The following is a description of a gene set: A nearly universal metabolic pathway in which the acetyl group of acetyl coenzyme A is effectively oxidized to two CO2 and four pairs of electrons are transferred to coenzymes. The acetyl group combines with oxaloacetate to form citrate, which undergoes successive transformations to isocitrate, 2-oxoglutarate, succinyl-CoA, succinate, fumarate, malate, and oxaloacetate again, thus completing the cycle. In eukaryotes the tricarboxylic acid is confined to the mitochondria. See also glyoxylate cycle. Human Gene Set: GOBP_TRICARBOXYLIC_ACID_CYCLE species: Homo sapiens, and this is the list of marker genes: ACO2, CSKMT, MDH1, DLAT, SUCLA2, IDH3G, SDHAF4, PDHA2, DLST, SDHB, SDHC, NNT, MDH1B, SUCLG2, IDH3A, SDHAF2, CS, IDH3B, KGD4, PDHA1, SDHD, FH, PDHB, SDHA, ACO1, OGDH, MDH2, COL6A1, IDH1, SUCLG1, OGDHL, NDP, IDH2